The following is a description of a gene set: Genes predicted to be targets of miRBase v22 microRNA hsa-miR-3976 in miRDB v6.0 with MirTarget v4 prediction scores > 80 (high confidence targets). species: Homo sapiens Human Gene Set: MIR3976 from publication Chen Y, Wang X (PMID 31504780), and this is the list of marker genes: TMEM196, HEPN1, MOB1B, P2RY14, MTMR4, SEMA3F, TRIM66, CSRNP2, PIWIL1, ITGBL1, NOVA1, GUCY1A1, MAGI2, MMRN1, IRAK1BP1, PRR14, BTNL3, NRXN1, ZDHHC8, MMUT, DPPA4, GAD1, PRKACB, SESTD1, NUDT11, TMEFF2, TAS2R13, AHCTF1, GJB2, HYKK, MPV17L2, SUCNR1, WDR12, RNPEP, CELF4, THSD7A, SLC6A1, PALS1, PTPN21, SNRNP40, KLHL8, C1RL, PLPP6, FAM13C, PCNA, CCDC126, DTD2, SPAG9, SFRP4, TTC22, CAP1, ATXN1L, CCSER2, LRCH4, CRPPA, SRSF10, PHLDB2, MAP3K2, FYB1, PPP3R1, SCN2A, GPC4, LAMP2, HIF3A, SMC4, ZNF571, CYP7A1, SCML1, ZNF641, KRT76, DTL, ADCY5, SATB2, HDAC9, AAK1, PCLO, MEX3C, ARMC2, NIPA1, TMTC3, GPC6, FAM76A, PPARGC1A, TMLHE, ISCA1, EXOSC3, XCL1, RAB39B, SP4, RNASE4, FSTL1, TET3, CNTN3, EFNA3, XKR6, GPR34, UGT2A3, LYSMD2, PIK3IP1, THAP6, ANO1, RBM44, PSMA5, IFT22, STX16, ATL2, TADA1, IFIT2, KRT38 (keratin 38), IL20RA, ABCA9, BCL7A, DCT, NALCN, KIAA1210, TGM2, SFXN2, NOC3L, FBXL3, PJA2